Given this list of marker genes Gng2, Ncald, Gng3, Plcb3 (phospholipase C, beta 3), Calm3, Gng10, Grik5, Gngt1, Gnb4, Gnb5, Gng12, Calm2, Gng7, Plcb2 (NCBI Gene Id 99018), Gnb2, Dlg4, Gng11, Grik1, Gnb1, Gnb3, Dlg1, Gng13, Grik4, Dlg3, Plcb1, Gng8, Grik3, Gng4, Grik2, Gng5, Calm1, Gngt2, here is a description of the gene set: Activation of kainate receptors upon glutamate binding studied in species Mus musculus Mouse Gene Set: REACTOME_ACTIVATION_OF_KAINATE_RECEPTORS_UPON_GLUTAMATE_BINDING